Given this list of marker genes UBA2, PIAS1, RWDD3, MUL1, PIAS3, ARNT, HDAC4, SAE1, PIAS4, CDKN2A, RASD2, GNL3 (G protein nucleolar 3), TOLLIP, here is a description of the gene set: Any process that activates or increases the frequency, rate or extent of the addition of SUMO groups to a protein. species: Homo sapiens Human Gene Set: GOBP_POSITIVE_REGULATION_OF_PROTEIN_SUMOYLATION